Given this list of marker genes Adprs, Apex1, Lig1, here is a description of the gene set: Reactome Pathway: POLB-Dependent Long Patch Base Excision Repair part of: Resolution of AP sites via the multiple-nucleotide patch replacement pathway This event has been computationally inferred from an event that has been demonstrated in another species.<p>The inference is based on the homology mapping from PANTHER. Briefly, reactions for which all involved PhysicalEntities (in input, output and catalyst) have a mapped orthologue/paralogue (for complexes at least 75% of components must have a mapping) are inferred to the other species. electronically inferred by orthology from the curated human pathway studied in species Mus musculus